Given this list of marker genes CAPN12, CLPX (caseinolytic mitochondrial matrix peptidase chaperone subunit X), LZTS2, MEGF8, SLF2, SUSD2, RGS16, COL25A1, XKR6, CD226, RIMBP2, COA5, CSF1, IGSF3, PPP1R12A, NRP1, TAGLN, CTLA4, KIF26A, RORB, IRX6, IL2RG, ESPN, WBP2NL, XRN2, CNKSR1, CASP14, RCL1, TTBK1, FOXL1, RTP3, FAM107B, PDCD4, TSPAN18, ANKRD63, BANF2, CTTNBP2, HRG (NCBI Gene Id 3273), FAM83G, SIN3A, SLC25A17 (solute carrier family 25 member 17), SCN4A, BRD8, HNRNPU, TUBB, DEFB119, STK36, PPM1N, LRRC2, AEBP2, STAG3, LRPPRC, CCNJL, DEPP1, RHOT1, LRRC10B, FAM120C, GALNT9, TNS1, PFKFB4, LIMD2, LMNTD2, FBXO17, RC3H2, HAO1, SALL4, CRYM, TOX2, ICAM5, HMOX2, TASOR, SYTL3, CASS4, SOX11, COL22A1, HNRNPH1, ZBTB12, PIP5K1A, PTP4A2, LDHAL6B, GP1BA, MYL9, POLR3A, LRIT1, EARS2, GRIP2, BEST2, CXCL17, MNX1, SAMD12, GNG4, GOLGA4, PSMD11, LRRTM2, FBXW9, CDK12, PKP3 (NCBI Gene Id 11187), SENP2 (SUMO specific peptidase 2), TM9SF3, PITX3, NUDT4, LMCD1, AVIL, DMKN, CORO6, CCDC71, GPR17, PHETA2, BEND7, DNAJC11, LRRIQ4, SRSF11, CCL22, GAREM1, RCHY1, WAPL, CASP7, SMCO2, SUZ12, MAPRE2, CATSPERZ, NPC1L1, ARSI (NCBI Gene Id 340075), PELI2, KCNK1, SLC1A1, CELA1, AADAT (aminoadipate aminotransferase), GRHL3, ZC2HC1B, TUFT1, CPB1, TBX4, MUC13, NINJ2, STMN2, SERPINE1, IRAK3, ZNF280B, TWIST2, CRABP1 (cellular retinoic acid binding protein 1), CD93, STARD4, ANKRD49, SPTBN4, DNAH5, IGHMBP2, GNAQ, NANOS1, PTGS1, NLRP14, TFAP2C, FGA, AMER3, CFAP45, MED14, C17orf50, NBEA, IGFBP4, ELF2, PPP1R13L, USP49, TSKS, TGM5, CSTF2, DLG5, ASH2L, UBE2D1 (NCBI Gene Id 9335), PPIA, TCAP, CDH1 (NCBI Gene Id 999), HSD17B2, IGSF9B, C5orf15, SLC6A19, TMEM217, RASL11A, CHL1, VCAN, ITIH2, TGIF2LX (NCBI Gene Id 90316), PNISR, CELA2A, SOX13, EPHB2, IKZF2, RILPL2, GPBP1L1, CCAR1, HSPB3 (NCBI Gene Id 8988), CRACD, TPM3, C9orf152, ZNF451, EVA1C, SPTB, WDR18, RPS9, CLIP4, KLF11, here is a description of the gene set: CD8 T cells play a crucial role in immunity to infection and cancer. They are maintained in constant numbers, but upon stimulation with antigen undergo a developmental program characterized by distinct phases encompassing the expansion and then contraction of antigen-specific populations, followed by the persistence of long-lived memory cells. Although this predictable pattern of a CD8 T cell response is well established, the underlying cellular mechanisms regulating the transition to memory remain undefined. Here we show that TRAF6, an adapter protein in the TNF-receptor (TNFR) and IL-1R/TLR superfamily, regulates CD8 T cell memory development following infection by modulating fatty acid metabolism. We show that mice with a T cell-specific deletion of TRAF6 mount robust primary CD8 T cell effector responses, but have a profound defect in their ability to generate memory. This defect is CD8 T cell intrinsic and is characterized by the disappearance of antigen-specific cells in the weeks following primary immunization. Microarray analyses revealed that TRAF6-deficient CD8 T cells from early timepoints following immunization exhibit altered expression of genes that regulate fatty acid metabolism. Consistent with this, activated CD8 T cells lacking TRAF6 are unable to upregulate mitochondrial β-oxidation in response to growth factor withdrawal in vitro. Treatment with drugs that induce fatty acid oxidation enabled CD8 T cell memory generation in the absence of TRAF6. Remarkably, these treatments also increased CD8 T cell memory in wild type mice, and consequently were able to significantly improve the efficacy of an experimental anti-cancer vaccine. from publication Pearce EL, Walsh MC, Cejas PJ, Harms GM, Shen H, Wang LS, Jones RG, Choi Y (PMID 19494812) species: Homo sapiens Genes down-regulated in comparison of wild type CD8 effector T cells at day 6 versus those from mice defficient for TRAF6 at day 6. Human Gene Set: GSE15750_WT_VS_TRAF6KO_DAY6_EFF_CD8_TCELL_DN